Given this list of marker genes Nudt14, Adprm, Nudt5, Nudt6, Trpm2, Nudt9, here is a description of the gene set: species: Mus musculus Mouse Gene Set: GOMF_ADP_RIBOSE_DIPHOSPHATASE_ACTIVITY Catalysis of the reaction: ADP-ribose + H2O = AMP + D-ribose 5-phosphate.